Given this list of marker genes Sybu, Zdbf2, Slain2, Parp9, Man1c1, Zfp131, Smim3, Pebp4, Sos1, Ranbp3l, Serpinb9, Lsm14a, Grm5, Adamts1, Ost4, Ppp3r1, F2r, Lamtor5, Mrgprb1, Sp1 (trans-acting transcription factor 1), Tspan2, Zfp280c, Nufip2, Dach2, Gch1, Dlg3, Nup58, Id4, Apln, Slc12a6, Cfhr4, Ets1, Zfp937, Rabgap1, Tpp2, Triobp, Nfkbiz, Olr1, Rock2, Gm128, Hbp1, Nsd1, Rnf44, Pi4k2b (NCBI Gene Id 74082), Dusp2, Spred1, Snx7, Spire2, Lztfl1, Zbtb7a, Rnf38, Fgfrl1, Crh, Wnk3, Rab8b, Tmtc3, Twf1, Ccna1, Dnm1l, Epyc, Pknox1, Atl3, Slc37a1, Tfdp1 (NCBI Gene Id 21781), Samd4b, Mad2l1, Krr1, Kat6a, Slc2a2, Arhgap6, Ppp1r3f, Slc8a1, Sh3bgrl2, Neil2, Jchain, Ifitm10, Rtn1, Foxj2, Mfsd14a, Ecm2, Hlf (NCBI Gene Id 217082), Ppfia1, Fgf9, Gas1, Tead1, Scn8a, Zeb2, Plau, Cadm2, Wdr77, Cntln, Pheta2, Cyp2c40, Hif1a, Nr1d2, Epb41l1, Casz1, Tafa5, D17H6S56E-5, Zmynd11 (NCBI Gene Id 66505), Igsf9b, Clip4, Serpinb11, Zic3, Pxn, Epb41l2, Chchd3 (NCBI Gene Id 73342), Bmper, Thoc2, Gucy2f, Phyhipl, Zc3h12c, Magi3, Atxn1, Med12, Slf1, D16Ertd472e, Fat1, Ndufa7, Tmem106b, Chsy3, Ice1, Kdm6a, Crebrf, Cd226, Rgcc, Mtmr3, Cyp2c67, Hs6st2, Akirin1, Tbc1d12 (NCBI Gene Id 209478), Pcf11, Cyp2c68, Rora, Sptbn1, Hnrnpdl, Fbxo38, Homer1, Bend4, Lrig3, Gdap2, here is a description of the gene set: Mouse Gene Set: MIR_190A_3P Genes predicted to be targets of miRBase v22 microRNA mmu_miR_190a_3p in miRDB v6.0 with MirTarget v4 prediction scores > 80 (high confidence targets). from publication Chen Y, Wang X (PMID 31504780) species: Mus musculus